The following is a description of a gene set: Reactome Pathway: Regulation of clotting cascade species: Homo sapiens part of: Coagulation pathway The coagulation pathway is tightly regulated by numerous mechanisms to maintain hemostatic balance and ensure effective clot formation. Dysregulation of any component can lead to bleeding or thrombotic disorders., and this is the list of marker genes: PF4, F3, F2, F7, SDC4, PROC, VWF, SERPING1, HSPG2, CD177, GPC3, PROS1, GPC4, SMPD1, APP, GP1BA (NCBI Gene Id 2811), GPC5, F5, SERPINE1, F2R, PRTN3, GPC6, AGRN, SERPINA10, PF4V1, KNG1, SDC2, ANO6, THBD, ANO5, GPC1, PROCR, SERPINA5, GP9, KLKB1, F9, ADAMTS13, SDC3, GP5, F10, F12, SERPINE2, SERPINC1, GPC2, GP1BB, SERPIND1 (serpin family D member 1, NCBI Gene Id 3053), TFPI, PROZ, F11, F8, SDC1